The following is a description of a gene set: Mouse Gene Set: GOBP_SHORT_TERM_MEMORY The memory process that deals with the storage, retrieval and modification of information received a short time (up to about 30 minutes) ago. This type of memory is typically dependent on direct, transient effects of second messenger activation. studied in species Mus musculus, and this is the list of marker genes: Calb1, Drd4, Rcan2, Pde5a, Brinp1, Rcan1, Cux2, Slc2a4, Mdk, Lcn2, Aph1b, Pdcd10, Serpinf1, Adnp, Grm7, Npas4, Comt, Aph1c, Ptchd1 (NCBI Gene Id 211612)